The following is a description of a gene set: part of: Gene expression (Transcription) Reactome Pathway: Gene Silencing by RNA species: Mus musculus This event has been computationally inferred from an event that has been demonstrated in another species.<p>The inference is based on the homology mapping from PANTHER. Briefly, reactions for which all involved PhysicalEntities (in input, output and catalyst) have a mapped orthologue/paralogue (for complexes at least 75% of components must have a mapping) are inferred to the other species. electronically inferred by orthology from the curated human pathway, and this is the list of marker genes: Tnrc6c, Ago4, Ran, Tarbp2